Given this list of marker genes SLC38A9, SCAND3, LGR5, GNA12, ZNRF3-IT1, MAPK4, ISYNA1, TERF2IPP1, ENSG00000251095, RFX6, MAST4-AS1, MAP7D2, GABRA4, TUBA5P, OVCH2, LINC01205 (NCBI Gene Id 401082), OFCC1, TP63, IL1RAPL2 (NCBI Gene Id 60679), CTBP2P8, ENSG00000256615, PRSS12, OR8G1, ZNRF3, LINC02378, ZNF723, NALCN-AS1, AP1S3, ALDH7A1, DSC3, FAM41C, GPR87, SMAGP, KCNG1, FAM118A, SLC13A4, CYP2J2, TMEM150C, LINC02253, GRAMD2A, NRXN3, CRISPLD1, TRPV4, LINC01162, L1TD1, KANK1, SIGLEC6, RASSF6, ADCY2, SLC28A2, APELA, MIR205HG, ZYG11A, CLCA2, TENM3, LRATD1, CCDC54-AS1, LRP2, EDARADD, HS6ST2, MCOLN3, FTLP14, LINC01210, SLC6A4, SLC27A2, CYP4F35P, TENM3-AS1 (NCBI Gene Id 90768), ATP6V0A4, VSTM5, BFSP2-AS1, TTPA, LINC01618, GCNT4, HSPD1P6, FRMD6, CDH8-AS1, SLC52A3, POF1B, ANKRD65, SLC22A11, POTEKP, SLC13A3, here is a description of the gene set: The gene expression program underlying the specification of human cell types is of fundamental interest. The study authors generated human cell atlases of gene expression and chromatin accessibility in fetal tissues. For gene expression, the study authors applied three-level combinatorial indexing to >110 samples representing 15 organs, ultimately profiling ~4 million single cells. The study authors leveraged the literature and other atlases to identify and annotate hundreds of cell types and subtypes, both within and across tissues. Our analyses focused on organ-specific specializations of broadly distributed cell types (such as blood, endothelial, and epithelial), sites of fetal erythropoiesis (which notably included the adrenal gland), and integration with mouse developmental atlases (such as conserved specification of blood cells). These data represent a rich resource for the exploration of in vivo human gene expression in diverse tissues and cell types. from publication Cao J, O'Day DR, Pliner HA, Kingsley PD, Deng M, Daza RM, Zager MA, Aldinger KA, Blecher-Gonen R, Zhang F, Spielmann M, Palis J, Doherty D, Steemers FJ, Glass IA, Trapnell C, Shendure J (PMID 33184181) Human Gene Set: DESCARTES_FETAL_PLACENTA_SYNCYTIOTROPHOBLASTS_AND_VILLOUS_CYTOTROPHOBLASTS Marker genes curated from the annotated cluster as represented in the Descartes Human Gene Expression During Development database. studied in species Homo sapiens